Given this list of marker genes ARL6IP6, SREK1, RPS6KA5, NUMB, RALA, ZC3HAV1L (NCBI Gene Id 92092), OAZ1, ANGEL2, ZNF503, DDIT4, LRP1B, KPNA4 (NCBI Gene Id 84857), ASB3, LVRN, GPD2, MAST4, SECISBP2L, ITGB6, CCNG2, GPC6, SLC4A7, SKIDA1, TCF12, PPEF2, GRM5 (NCBI Gene Id 2915), ACBD3, IGSF3, MDFIC, MBIP, LIN7A, ABCA5, ADAM30, CCNB1 (NCBI Gene Id 891), RNF217, C21orf91, PLEKHH2, MIER3, PTBP3, CHN1, TRA2B, CBFB, S1PR1, CHST9, TNFRSF21, CA8, FZD3, BRWD1, ACBD5, SANBR, GSE1, A1CF, ARMCX3, COMMD3-BMI1, STYX, PRPF39, AIDA, ZNF747, SMAD5, CLDN12, CFDP1, RIMOC1, UBE2A, CERS6, CFAP44, ACTN4, RIC1, DUSP7, CCDC117, MZT1, IGF1, CSGALNACT2, EVI2A (ecotropic viral integration site 2A), PSMC2, TFAM, CMPK2, BTF3L4, LANCL1, ERC2, SDC2, ZBTB10, EDIL3, GAPVD1 (NCBI Gene Id 26130), LPP, PAX5, FNDC3B, TMEM200A, MFSD8, NOS2, LMX1A, IGF2BP3, BBS10, RAP1A, PAPOLG, RC3H1, ZBTB41, ACAT2, CIAO2A, PITX2, ZNG1E, KATNBL1, ABI3BP, PDZRN4, TLCD4, HMBOX1, PRKAG2, NR2C1, SCAMP1, SMAD9, SCAI, EIF2AK2, REV3L, ATXN2, GCC2, BMI1, ZFAND5, ZDHHC2, B3GALT5, AFDN, CFL2 (cofilin 2), ZNF680, FNIP2, TRIM2, COL11A1, CRACD, TTC19, GUCY1B1, LRRC7, MECP2, ZBTB11, MMP16, CAMSAP2, PRPF40A (pre-mRNA processing factor 40 homolog A), NTF3, ARL13B, CD99, PPP1R2, PPP1R27, RNF149, NOTUM, ANAPC1, ZEB2, URI1, RBBP8, KRT28, ADAM22, RHOQ, MAP4K4, TBCK, ODAPH, PHYHIPL, HLTF, HDAC9, RFC3, ADH5, GOPC, ZNG1F (Zn regulated GTPase metalloprotein activator 1F), PDE4D, SCN1A, SAMTOR, APPBP2, FIGN, ZNF652, HIPK1, ZBTB44, CACUL1, PTPRG, UEVLD, SYNM, RAB8B, TBCA, DEFA6, FZD5, MEIS2, MCF2L2, RGPD4, ZNF148, OGFRL1, ZNG1C, GTF2I, DYNC1LI2, TPM3, RGPD5, ARK2N, AFTPH, GATM, MGARP, BTG2, U2SURP, SPATA6L, KIAA1586, RGS7BP, UTP3, GPATCH11, FGD4, RASSF8, SUMF1 (NCBI Gene Id 285362), SFT2D1, POLR2H, PCLO, SERINC5, TRUB1, LACTB, LSAMP, ZDHHC15, ALG11, SEC24A, PDCD5, DIP2B, SYTL5, MAML1, RGPD6, DNAJB4, DHRS1, ZBTB20, MBNL3, GABRA4, PREX2, ATP11A, PLEKHG1, MMD, NUP50, NRXN1, UGT8 (NCBI Gene Id 7368), RETREG1, SH3D19, CRIPT, MINDY2, LRRC4B, CCDC179, MARCHF6, SOX5, TTC13, DOLPP1 (dolichyldiphosphatase 1), CYBRD1, SACS, SFMBT1, BCL2L2, SRP9, ZNF454, GASK1A, CEP350, FOXG1, PRRC1, FYB2, FRMD5 (FERM domain containing 5), CHRNA7, ZBTB25, KLF7, SDF4, PRKG1, PDE1C, RHPN2, NOTCH2, C6orf120, UBA6, GRID2 (NCBI Gene Id 2895), CTNNA3, RESF1, SCN8A, JARID2, MIER1, TP53INP1, ELL2, EEA1, FAM221A, EXOC5 (NCBI Gene Id 29024), SEC22C, AGTR1, FBXL3, RRAGD, AK3, DAAM1, SPDYE1, PCDH11Y, BOD1L1, GPR85, ADGRB3, TRPC5, PROK2, TMEM255A (NCBI Gene Id 55026), CAPN2, WDR26, CLVS2, LARP4, GRM7, METTL8, KLF10, CDK6, STXBP5, PRKAA2, GPALPP1, NAV2, PPHLN1, NEDD4L, ADAMTS1, PAQR9, PGRMC2, FAM199X, RICTOR, NAT1, ANKRD26, GABPB1, LCOR, HOMER1, FSBP, ATXN7L1, RO60, CBX3, HTR2C, CISD2, ARID2, LACTB2, ZCCHC8, GULP1, TIFAB, PPP5C, ZNF492, NFAT5, DYNC1I2, WDR7, IKBIP, TMTC1, HOXD13, CSNK1D (NCBI Gene Id 1453), C5orf24, CACNA2D3, FAM135A, CD163, FZD7, RMND5A, LCTL, MTA1, SNX16, SIX4, ARFRP1, NDFIP2, NUP160, ETF1, ZNF486, HOOK3, ZNG1B, RORA, C11orf87, YIPF5, GTF3C3, RAB27B, FLRT3, PGAM1, TMTC3, KIF20B, KLF8, RFX7, SLU7, CEP120, PROSER1, GCNT1 (NCBI Gene Id 2650), GUCY1A2, ANKRD10, PTGFRN, MAGT1, SF3A1, BBX (NCBI Gene Id 56987), ACVR2B, SLCO5A1, MTFR1, ZBTB8A, BNIP3, DIAPH3, PRKAA1, EPB41L5, TRIM9, CCSER1, GPR155, SERINC3, MTF1 (metal regulatory transcription factor 1), DPY19L3, AQP3, DUS4L, UGDH, C3orf38, TMEM167B, CNTN1, ZNF608 (zinc finger protein 608), ZNF792, SCN3A (sodium voltage-gated channel alpha subunit 3), FAM133A, GSTCD (glutathione S-transferase C-terminal domain containing), BEND7, DENND1B (NCBI Gene Id 54530), HECA, PPARG, SDE2, TFDP3, LMCD1, TMEFF2, NEGR1, SLC24A3, MMUT, ZNF326, RAP2A, NDC1 (NCBI Gene Id 55706), THSD7A, UNC80, SETD2, TMED7, ZDHHC21, FGFR1OP2 (FGFR1 oncogene partner 2), HNRNPDL (NCBI Gene Id 9987), CCDC47, GNAQ, NCKAP1, MBNL2, FBXO22, TXLNG, FGL2, WDR47 (WD repeat domain 47), KLRD1, CCDC50, SAMD8, ME1, MED6, NRG4, SESTD1, KCNJ3, WAPL, BTG3, AHSA2P, GRIP1, RNF138, FEM1C, TMEM135 (NCBI Gene Id 65084), LRRTM3, SPOCK3, SRSF3, PPP1R9A, MAP9, ACADL, DNAJB14, GOLGA6L2, TMEM65, ZRANB2, XPNPEP1, ARRDC4, SNX30, CLCN4, BRWD3, TOLLIP, MEX3D, SSR3 (NCBI Gene Id 6747), GABPA, SNAP91, MIGA1, PRELID2, SENP1, TRAM1, MYCN, MFN1, DCDC2, RGPD8, SRSF6, SPAG9, STEAP2, ITGAV, SCARF1 (NCBI Gene Id 8578), CAMLG, DTWD2, SMG1, PRP4K, ZNG1A, EPHA3, KL, NAA30, AP1AR, ANKRD46, NFKB1 (nuclear factor kappa B subunit 1), C9orf40, CCNY, CCP110, MAST3, ZNF559, SLAIN1, FMNL2, GLIPR1, MIDEAS, LATS1, ANKRD22, SLC30A5, ADAMDEC1, METTL6, PCDH11X, IKZF2, NUP54, SCML2, TRPC1, PTPRR, CARF, here is a description of the gene set: Human Gene Set: MIR548AB Genes predicted to be targets of miRBase v22 microRNA hsa-miR-548ab in miRDB v6.0 with MirTarget v4 prediction scores > 80 (high confidence targets). from publication Chen Y, Wang X (PMID 31504780) species: Homo sapiens